The following is a description of a gene set: Mouse Gene Set: GOMF_PHOSPHATIDYLCHOLINE_FLIPPASE_ACTIVITY Catalysis of the movement of phosphatidylcholine from the exoplasmic to the cytosolic leaflet of a membrane, using energy from the hydrolysis of ATP. studied in species Mus musculus, and this is the list of marker genes: Abca3, Atp10b, Atp8b2, Atp8b1 (NCBI Gene Id 54670), Atp10a, Atp8b5